The following is a description of a gene set: species: Homo sapiens Human Gene Set: HAY_BONE_MARROW_EARLY_ERYTHROBLAST from publication Hay SB, Ferchen K, Chetal K, Grimes HL, Salomonis N (PMID 30243574), and this is the list of marker genes: PLTP, PNPO, NMU, KIT, MRPS23, RPP40, UQCRH, MICOS10, EXTL2, PNMT, MRPS26, CLNS1A, SRM, FAM136A (family with sequence similarity 136 member A), FAM89A, NDUFC2, DCTPP1, FBL, GATA2-AS1, CDH1, SLC27A2, PABPC4, NME1, MRPS25, DES, AK2, NMI, NPM3, MYC, ECHS1, SDHAF3, AIG1, NDUFAF2, DMAC1, OLA1, TFAM, RPL23, SLC39A4, MDH2 (malate dehydrogenase 2), CASP3, APOC1, RRP9, FSCN1, PHF6, EIF1AX, GTF3A, CMSS1, MUC1, HNRNPC (NCBI Gene Id 3183), DHRS11, MYB, CXADR, AHCY, MRPL52, CYP2E1, COL6A5 (NCBI Gene Id 256076), GAL (NCBI Gene Id 51083), NHP2, GRTP1, PPA1, CHCHD2, PRMT1, NPM1, WDR43, COQ8A, INTS13, PMP22, HDAC7 (histone deacetylase 7), TMEM97, CASP6, UNG (uracil DNA glycosylase), TUFM, MORF4L2, DNAH14, ABO, ATP5MK, SORD, CNRIP1, PVT1, GGCT, SELENOH, PGAP4, CENPV, TRIP6, GCSH, SLC12A6, CCDC26, DNPH1, KCNK5, PEBP1, GNL3, MGST2, RPL37A (NCBI Gene Id 6168), C1QBP, GSTM3